The following is a description of a gene set: studied in species Mus musculus Mouse Gene Set: GOBP_POSITIVE_REGULATION_OF_FIBROBLAST_GROWTH_FACTOR_PRODUCTION Any process that increases the rate, frequency or extent of the appearance of a fibroblast growth factor due to biosynthesis or secretion following a cellular stimulus, resulting in an increase in its intracellular or extracellular levels., and this is the list of marker genes: Aif1, Stat5b (NCBI Gene Id 20851), Ptgs2, Ccm2l, Rock2 (Rho-associated coiled-coil containing protein kinase 2), Heg1